Given this list of marker genes DCHS1, GCNT3, SOX8 (NCBI Gene Id 30812), GZF1, FGF8, NOG, FGF10, BMP7, ADAMTS16, HNF1A, AGT, WT1, GDNF, WNT7B, IRX3, IRX1, LIF, CALB1, KLHL3, CTNNB1, AGTR2, WNT11, TCF21, HS3ST3A1, OSR1, GCNT1, LHX1, FGF1, WNT2B, HOXA11, KIF26B, LGR4, EYA1, DLG1, SMAD4, AHI1, GATA3, PBX1 (NCBI Gene Id 5087), TMEM59L, ILK, PAX2, SIX2, GREM1, WWTR1, WNT6, SIX1, HOXD11, PKD2 (NCBI Gene Id 5311), WNT1, BMP2, BMP4, MAGED1, SOX4, FRAS1, ZMPSTE24, STAT1, HNF1B (HNF1 homeobox B), GPC3, FGF2, ASXL1 (NCBI Gene Id 23393), BCL2, VEGFA, LRRK2, ERBB4, NPHP3, LAMA5, LZTS2, GLI3, PPP3CA, TACSTD2, PKD1, PTCH1, CTNNBIP1, VANGL2, SHH, SALL1, WNT9B, FOXD1, WNT4, PRKX, MYC, HS3ST3B1, GREB1L, NPNT, HOXB7, TGFB1, WNK4, PAX8, HES5 (hes family bHLH transcription factor 5), SOX9, IRX2, SMO, HS2ST1, GCNT4 (glucosaminyl (N-acetyl) transferase 4), FOXJ1, SIX4, HES1, BASP1, CITED1, here is a description of the gene set: Morphogenesis of a kidney. A kidney is an organ that filters the blood and excretes the end products of body metabolism in the form of urine. Human Gene Set: GOBP_KIDNEY_MORPHOGENESIS species: Homo sapiens